The following is a description of a gene set: Human Gene Set: GOCC_SPECIFIC_GRANULE_LUMEN studied in species Homo sapiens The volume enclosed by the membrane of a specific granule, a granule with a membranous, tubular internal structure, found primarily in mature neutrophil cells. Most are released into the extracellular fluid. Specific granules contain lactoferrin, lysozyme, vitamin B12 binding protein and elastase., and this is the list of marker genes: CYFIP1, RETN, SLPI, ACAA1, CRISP3, LRRC7, TIMP2, LYZ, LTF, QSOX1, OLFM4 (olfactomedin 4), FRK, PTX3, QPCT, ERP44, CANT1, ARG1, DOCK2, GGH (NCBI Gene Id 8836), ORM2, ARMC8, RAB27A, AOC1, LRG1, NFKB1, KPNB1, LCN2, CTSZ, CEP290, NEU1, HP, OSCAR, MMP8, JUP, VCL, GSDMD, CRACR2A, DNASE1L1, NIT2, GHDC, PDXK, CHIT1, CFP (NCBI Gene Id 5200), DEFA4, ELANE, ORM1 (NCBI Gene Id 5004), CTSD, CHI3L1, PRG3, CXCL1, CAMP, ILF2, PTPN6, B2M, SPTAN1, TOLLIP, BPI, TCN1, FOLR3, CNN2, PGLYRP1, HPSE